The following is a description of a gene set: species: Mus musculus Mouse Gene Set: chr19D3, and this is the list of marker genes: Prdx3, Nanos1, Gm50440, Gm46652, Kcnk18, Gm20762, Mplkipl1, Rab11fip2, Vax1, Gm50357, 2700089I24Rik, Prlhr, Fam204a, Gm22520, Zfp950, Pdzd8, E330013P04Rik, Gm9529, Csf1r-ps, Gm19956, Gm33756, Shtn1, Cacul1, Slc18a2, Gm15959, Gm9276 (predicted gene 9276), Grk5 (NCBI Gene Id 14773), Gm5521, Gm18161, Gm18999, Gm4242, Gm22365, Emx2, Emx2os, Rps12-ps3, Csf2ra, Dennd10, Eif3a, Gm4219, Sfxn4